The following is a description of a gene set: part of: Regulation of T cell activation by CD28 family Programmed cell death protein 1 (PD-1) is a crucial inhibitory receptor that regulates T cell receptor (TCR) signaling and plays a vital role in maintaining immune homeostasis. PD-1 exerts its suppressive effects both directly, by inhibiting early activation events that are otherwise enhanced by co-stimulatory signals like CD28, and indirectly, by reducing interleukin-2 (IL-2) production, which is essential for T cell proliferation and survival. Upon ligation, PD-1 inhibits the expression of key survival and differentiation factors, such as Bcl-xL, and downregulates transcription factors that are central to effector T cell function, including GATA-3, T-bet, and Eomes. Mechanistically, PD-1 recruits the tyrosine phosphatases SHP-1 and SHP-2 to the immune synapse, leading to the dephosphorylation of critical signaling molecules like the CD3-zeta chain, PI3K, and AKT, thereby attenuating TCR signaling and inhibiting T cell activation and function. studied in species Homo sapiens Reactome Pathway: Co-inhibition by PD-1, and this is the list of marker genes: BRD4, RBBP7, PSMD2, H2AJ, LCK, PRKAA2, MYCN, PSMC3, PRKAG1, PTPN11, H2AC7, CSNK2A2, EPAS1, EP300, RNF5, NFKB2, H2BC3, HLA-DQA2, H2BC4, EZH2, YWHAG, PSMA4, PSMD13, H2BC5, AGO4, MIRLET7A1, BTRC, CD247, AGO2, CD274, HLA-DPA1, TRBC1, UBC, PSMA2, FOS, H2BC11, MOV10, PSMD7, MIR340, PDCD1LG2, NFE2L2, PDCD1, H2BC12, TRAC, DPY30, CDK4, WDR5, TRBV7-9, HLA-DRB1, H2AX, TEAD2, CCND1 (NCBI Gene Id 893), H2AC18, IRF1, AGO1, MIR200B (microRNA 200b), PSMA7, PSMB1, H2BC26, UBB, PRKAB2, B3GNT3, PSMB7, WWTR1, H2BC13, HLA-DRA, ADRM1, MIR142, PSMD1, ERLEC1, TUSC3 (tumor suppressor candidate 3), PSMD11, H2AC14, RBBP4, HLA-DQB2, VCP, PRKAG3, CSK, MIR429, DAD1, CSNK2B, MAGT1, CD3D, KMT2C, H3C15, PSMB2, TMEM258, STT3A, H2AZ2, H2BC1, FOSB, PSMD12, PSMD6, RELA, STT3B, HLA-DPB1, GSK3B, TCF7L1 (NCBI Gene Id 83439), MIR34C, PSMA6, YAP1, H2AC4, MIR93 (microRNA 93), HLA-DRB4, PSMB3, H2BC21, ERLIN1, PSMC4, JUN, H2AC20, OST4, RPN1, CD3E, MIR140, MYC, RPN2, SEL1L, SKP1, RBX1, CUL1, PRKAA1, LEF1, HLA-DQA1, PSMC2, TNRC6C, H3C1, TNRC6B, SEM1, TEAD4, CTNNB1, PSMD3, MIR200C, H2BC9, OS9, UBA52, NFKB1, CD4, PSMB5, DDOST, JAK1, TRAV29DV5, H2BC12L, DERL3, TNRC6A, AGO3, ERLIN2 (NCBI Gene Id 140906), PSMC1, H3-3A, PSMA1, TRBV12-3, OSTC, PSMD14, TRAV19, STAT3, MIR152, PSMC5, RPS27A, ASH2L, SPOP, HLA-DQB1 (NCBI Gene Id 7924), TCF7, SUZ12, STAT1, CREBBP, KMT2A, COPS5, CSNK2A1, PSMA5, MIR34A, H2BC14, RBBP5, JUND, H2AB1, EED, PSMB6, H2BC17, MIB2, PSMA3, ATF3, TEAD3, MIR34B, TEAD1, NEK2, H2AC6, DERL2, MIR138-1, MIR424, PSMB4, PRKAB1, HLA-DRB3, TCF7L2, HIF1A, CD3G, DERL1, RNF185, H4C1, HLA-DRB5 (NCBI Gene Id 731247), CUL3, H2BC15, TRAV8-4, PTPN6, MIR148A, PSMC6, PSMD8, PRKAG2